The following is a description of a gene set: species: Mus musculus Mouse Gene Set: GOBP_URIDINE_TRANSMEMBRANE_TRANSPORT The directed movement of uridine, uracil riboside, across a lipid bilayer, by means of some agent such as a transporter or pore., and this is the list of marker genes: Slc28a2, Slc28a3, Slc29a1, Slc28a1, Slc29a2, Slc28a2b, Slc29a3